Given this list of marker genes Vegfd, Ccl5, Vegfb, Vegfc, Pgf, Swap70, Vegfa, here is a description of the gene set: Any process that increases the rate, frequency or extent of mast cell chemotaxis. Mast cell chemotaxis is the movement of a mast cell in response to an external stimulus. studied in species Mus musculus Mouse Gene Set: GOBP_POSITIVE_REGULATION_OF_MAST_CELL_CHEMOTAXIS